Given this list of marker genes CDK14, PCCA, IDH3B, SLC2A5, LRBA, DLG2, CNTNAP2, POT1, RFC1, ASIC2, GTF2E2, NOP56 (NOP56 ribonucleoprotein), TBL1X, ASNS, SSR3, CLASP2, STYXL1, CDC14B, here is a description of the gene set: In all, 85% of Ewing's sarcoma family tumors (ESFT), a neoplasm of unknown histogenesis, express EWS-FLI1 transcription factor gene fusions. To characterize direct target genes avoiding artificial model systems, we cloned genomic DNA from ESFT chromatin precipitating with EWS-FLI1. We now present a comprehensive list of 99 putative transcription factor targets identified, for the first time, by a hypothesis-free approach based on physical interaction. Gene-derived chromatin fragments co-precipitating with EWS-FLI1 were nonrandomly distributed over the human genome and localized predominantly to the upstream region and the first two introns of the genes. At least 20% of putative direct EWS-FLI1 targets were neural genes. One-third of genes recovered showed a significant ESFT-specific expression pattern and were found to be altered upon RNAi-mediated knockdown of EWS-FLI1. Among them, MK-STYX, encoding a MAP kinase phosphatase-like protein, was consistently expressed in ESFT. EWS-FLI1 was found to drive MK-STYX expression by binding to a single ETS binding motif within the first gene intron. MK-STYX serves as precedence for successful recovery of direct EWS-FLI1 targets from the authentic ESFT cellular context, the most relevant system to study oncogenic mechanisms for the discovery of new therapeutic targets in this disease. from publication Siligan C, Ban J, Bachmaier R, Spahn L, Kreppel M, Schaefer KL, Poremba C, Aryee DN, Kovar H (PMID 15735734) Human Gene Set: SILIGAN_TARGETS_OF_EWS_FLI1_FUSION_DN species: Homo sapiens Genes bound by EWSR1-FLT1 fusion and down-regulated in STA-ET-7.2 cells (Ewing's sarcoma) after knockdown of EWSR1-FLT1 by RNAi.